The following is a description of a gene set: part of: Plasma lipoprotein clearance This event has been computationally inferred from an event that has been demonstrated in another species.<p>The inference is based on the homology mapping from PANTHER. Briefly, reactions for which all involved PhysicalEntities (in input, output and catalyst) have a mapped orthologue/paralogue (for complexes at least 75% of components must have a mapping) are inferred to the other species. electronically inferred by orthology from the curated human pathway studied in species Mus musculus Reactome Pathway: HDL clearance, and this is the list of marker genes: Apoa1